The following is a description of a gene set: Genes down-regulated in macrophages differentiated in the presence of IL4 and dexamethasone for 5 days versus those subsequently treated with TGFB1 for 24h. from publication Gratchev A, Kzhyshkowska J, Kannookadan S, Ochsenreiter M, Popova A, Yu X, Mamidi S, Stonehouse-Usselmann E, Muller-Molinet I, Gooi L, Goerdt S (PMID 18453574) The goal of the study was to identify the effects of TGF-beta on primary human macrophages maturated under different conditions. studied in species Homo sapiens Human Gene Set: GSE7568_CTRL_VS_24H_TGFB_TREATED_MACROPHAGES_WITH_IL4_AND_DEXAMETHASONE_DN, and this is the list of marker genes: ANKRD45, ESYT3, SPATA9, ZNF462, AKR1B15, PROZ, IL2RA, CTSV, OR51B2, CCR8, NDUFV3, PSMD1, CHAC1, EMID1, GUCY1B1, PIK3R6, CD163, SCN4B, MYL4, PMFBP1, JPH4, SLC12A3, FITM1, ATP5MC2, REEP2, TRPV4, ATXN7L2, NKX6-1, CEP20, CARD10, THY1 (Thy-1 cell surface antigen), KLRC1, PHLDB1 (pleckstrin homology like domain family B member 1), NRGN, CLEC3B, RGS17, TNNI1, CCR6, LHFPL4, CFI, SLC6A18, BARHL2, ALX1, TPCN1, GJC1, HSBP1L1, FERMT2, RCE1, CDKL1 (NCBI Gene Id 8814), FAM171A2, HRH1, CENPV, CAV3, B4GALT2, ALOX12B, CRYBB2, GPR176, SLC7A7 (NCBI Gene Id 9056), CAMKV, XRCC2, CREB3L3 (cAMP responsive element binding protein 3 like 3), GATM, EPN1, PROC, SET, MTUS2, ARL13A, TAFA3, GATB, TMEM171, GBX2, GAL3ST1, CSDC2, RASSF7, DOCK3, TMEM119, FOXF2, LAMC1, RHCG, PLAG1, CLIC6, ALDOAP2, PAX7, DAW1, HSPA12B, NDUFA4L2, SCRT2, NRIP2, LRMDA, CIMIP2A, CLSTN3, ALPG, ZMYND15, MSX2, AMH, TNFRSF4, SPTB, EEF1E1, TMEM198, DCLK1, ENTHD1 (NCBI Gene Id 150350), PITX1, PYCARD, ATG4B, CLDN1, RBM24, PCGF2, PDE2A, MS4A18, PSMD14, UPK2, NEUROG3, ANGPTL2, TFAP2C, KLRG2, OAZ3, CUX2, MC2R, AQP7, SSC5D, CDH22, ASPH, JPH3, TMEM175, UCN, TOM1L1, CRB3, SIGLEC7, KLK5, HOXB2, TRIM7, UPK3B, GLOD5, IMP3, SEMA4A, PON1, OPN1LW (NCBI Gene Id 8261), SRRM4, PTGER1, ZCCHC24, NLGN1, APOA4, HCN1, TNFRSF14, TFF3, RTL8B, FAM81B, RARG, XCL1, GPR132, BMP7, ASTN1, CYP2B6, HSPBAP1, NOTCH3, SHOX2, FSTL3, DAB1, ITGB7, MYCN, CDH15, PLEKHA7, ABO, TIGD5, MOB3B, HROB, ZSWIM4, NF1, TFCP2L1, AP2M1, FAM83E, IL10, COL19A1, DXO, ISLR2, CYP2U1, RHBDL2 (NCBI Gene Id 94136), MORN4, COX6B1, USP2, GPR35, PDLIM1, USP14, CPPED1, EXOC5, RUSC2, EPHA2, LIPT1, S100A8, SH3RF1, SLC2A12, TCF15, SGPP2, OTX2, LDLRAD4, MAMLD1, JUND, HNRNPC, OC90, IGSF9